The following is a description of a gene set: Human Gene Set: GSE3994_WT_VS_PAC1_KO_ACTIVATED_MAST_CELL_DN species: Homo sapiens Bone marrow-derived mast cells were differentiated over 4-6 weeks using bone marrow from Pac-1+/+ and Pac1-/- littermate mice. Cell purity was 99% c-kit and Fc epsilon receptor positive as assessed by flow cytometry. Cells were stimulated by Fc epsilon receptor crosslinking using IgE-DNP/HSA for sensitization for 18 hours and DNP-HSA antigen for crosslinking for 2 hours. Gene transcript abundance was determined and scaled to 150 using alogorithms in MicroArray Analysis Suite Software 5.0 (Affymetrix). from publication Jeffrey KL, Brummer T, Rolph MS, Liu SM, Callejas NA, Grumont RJ, Gillieron C, Mackay F, Grey S, Camps M, Rommel C, Gerondakis SD, Mackay CR (PMID 16474395) Genes down-regulated in bone marrow-derived mast cells: wildtype versus ADCYAP1R1 knockout., and this is the list of marker genes: RMC1, TMEM41B, DNASE1L3, LDHD, GATA3, NEMF, GGT7, KBTBD11, EXOC4, CD28, CA8, GSN (gelsolin), AGPAT3, TERF2IP, IL20RB, EPSTI1, ENPP4, PSMF1, GSTT2, RBM10, PTK2B (NCBI Gene Id 5748), GALC, CYSLTR2, ARL4C, MDFIC, TYK2, GMEB2, SASH3, POLR3C, CNP, TMEM39A (transmembrane protein 39A), ARID5A, CALU, TMEM229B, SYNE2, POGLUT2, TBRG1, PAFAH1B1, FUCA2, BSCL2, SNX20, MLLT3, BBS9, CSNK1D, SPP1, NGLY1, ZMYM4, CPNE1, ODC1, CDH2, AFG3L2, SNX1, IL5, STOML1, GHSR, CAMK2D, ATG16L2, SATB1, SMO, GPRASP2, ESYT2, AGO2, KLHDC2, AP1B1, MMP1, IL21, ARHGAP17, SPSB4 (NCBI Gene Id 92369), EMB, ITGB3, FNTA, NISCH, SLAMF1, STAM, ARHGEF7, DNAJA4, CTNNB1, IL24, DNAJC21 (NCBI Gene Id 134218), TGDS, ZBTB25 (zinc finger and BTB domain containing 25), SLC15A2, MAP3K5, ERCC4, CLCC1, OSBP, STK33, MSRA (methionine sulfoxide reductase A), ADAM8, ZMAT3 (zinc finger matrin-type 3), EVL, ZIC1, MON2, TNFSF8, EML5, SSR3, RADIL, TRRAP (NCBI Gene Id 8295), LYRM1 (LYR motif containing 1), TASP1, SIGIRR, CTDSPL2 (NCBI Gene Id 51496), TSPAN6, MAP3K8, BCL2L11 (NCBI Gene Id 150819), ARAP1, CASZ1, ABHD4, MMP12, CDIN1, CLUAP1, KCTD12, ITSN2, EVC2, SNX9, CHSY1, LPP, USP50, UVRAG, NEK8, RFTN1, SUGP1, DESI2, VPS13B, KDM1B, SELL, MRPL1, PLA2G12A, CTSE, TRAM2, PGPEP1, ARHGEF19, SH3GL1, ECE1, ZNF804A, B4GALNT4, PAK6, TRAM1, GPC1, ABHD16A, UBE3B, IL4R, MICALL2, VPS39, PADI3, NFIL3, LAMA1, CREB3L2, NFE2L2, STIM1, CEPT1, SEC24C, NELFB, TRIM66, RIOK1, SOCS3, GTF3C3, WIPF2, DPH7, RND3, ARHGAP18, LY6E, CACNA2D4, NUB1, CASP4, RABEP2, PI4KA, CD5, CLEC10A, PTGER2, RBMS1, JAK3, CEP164, PTK6, GIMAP7, CD200, GPR18, EXOC6, ATG2A, TENT5C, ATIC, PNMA2, ENAM, CHD7, ZBTB43, ONECUT2, FBXO31, ARMCX3, SLC17A6, ZBTB17, LASP1, SBNO2, ABCB4, TOR2A, GPR89B, CSNK1A1, REN, RPAP3 (NCBI Gene Id 79657), TAF1B, PAN2